Given this list of marker genes MCM9, INHBA, DENND1B, PNP (purine nucleoside phosphorylase), RRP15, NUSAP1, SULF1, STK4, NAA25, EIF2AK1, COL1A1, KCMF1, GLCCI1, RAC1 (NCBI Gene Id 5879), TOP2A (DNA topoisomerase II alpha), DDX60, B3GALNT1, RALGPS2, STMP1, TBCE, FN1, COL11A1, GLRX3, RBM34, THAP6, INTS7, ATP2B1, FBN1, TRNT1, RORA, RMND1, FUT8, MRPL44, UBE2D2, COL10A1, SFRP4, RACGAP1, HMMR, FANCI, IFIT3, COL3A1, SGMS1 (NCBI Gene Id 93538), CPB1, CSTF2T, VCAN (versican), EPS15L1, COL5A2 (collagen type V alpha 2 chain), UNC5B, MELK, COL1A2, EPB41L3, RAB18, LRRC15, LRR1, ANLN, VOPP1, NBAS, LINC01614, ASPM, HDGFL3, TRIM59, MGAT2, CCNE2, PRR11, UBE2D1, TMEM107, CCT5, FAR2, CTHRC1, DTL, MLLT10, TIGAR, GDPD1, RET, here is a description of the gene set: species: Homo sapiens BACKGROUND: Invasive ductal and lobular carcinomas (IDC and ILC) are the most common histological types of breast cancer. Clinical follow-up data and metastatic patterns suggest that the development and progression of these tumors are different. The aim of our study was to identify gene expression profiles of IDC and ILC in relation to normal breast epithelial cells. METHODS: We examined 30 samples (normal ductal and lobular cells from 10 patients, IDC cells from 5 patients, ILC cells from 5 patients) microdissected from cryosections of ten mastectomy specimens from postmenopausal patients. Fifty nanograms of total RNA were amplified and labeled by PCR and in vitro transcription. Samples were analysed upon Affymetrix U133 Plus 2.0 Arrays. The expression of seven differentially expressed genes (CDH1, EMP1, DDR1, DVL1, KRT5, KRT6, KRT17) was verified by immunohistochemistry on tissue microarrays. Expression of ASPN mRNA was validated by in situ hybridization on frozen sections, and CTHRC1, ASPN and COL3A1 were tested by PCR. RESULTS: Using GCOS pairwise comparison algorithm and rank products we have identified 84 named genes common to ILC versus normal cell types, 74 named genes common to IDC versus normal cell types, 78 named genes differentially expressed between normal ductal and lobular cells, and 28 named genes between IDC and ILC. Genes distinguishing between IDC and ILC are involved in epithelial-mesenchymal transition, TGF-beta and Wnt signaling. These changes were present in both tumor types but appeared to be more prominent in ILC. Immunohistochemistry for several novel markers (EMP1, DVL1, DDR1) distinguished large sets of IDC from ILC. CONCLUSION: IDC and ILC can be differentiated both at the gene and protein levels. In this study we report two candidate genes, asporin (ASPN) and collagen triple helix repeat containing 1 (CTHRC1) which might be significant in breast carcinogenesis. Besides E-cadherin, the proteins validated on tissue microarrays (EMP1, DVL1, DDR1) may represent novel immunohistochemical markers helpful in distinguishing between IDC and ILC. Further studies with larger sets of patients are needed to verify the gene expression profiles of various histological types of breast cancer in order to determine molecular subclassifications, prognosis and the optimum treatment strategies. from publication Turashvili G, Bouchal J, Baumforth K, Wei W, Dziechciarkova M, Ehrmann J, Klein J, Fridman E, Skarda J, Srovnal J, Hajduch M, Murray P, Kolar Z (PMID 17389037) Human Gene Set: TURASHVILI_BREAST_DUCTAL_CARCINOMA_VS_LOBULAR_NORMAL_UP Genes up-regulated in ductal carcinoma vs normal lobular breast cells.